Given this list of marker genes IDUA, here is a description of the gene set: studied in species Homo sapiens Mucopolysaccharidosis type I (MPS I, Hurler syndrome, Hurler's disease, gargoylism, Scheie, Hirler-Scheie syndrome; MIM:607014, 607015 and 607016) is an autosomal recessive genetic disorder where there is a deficiency of alpha-L iduronidase (IDUA, MIM:252800), a glycosidase that removes non-reducing terminal alpha-L-iduronide residues during the lysosomal degradation of the glycosaminoglycans heparan sulphate and dermatan sulphate. In 1992, Scott and colleagues were able to clone and purify the gene that encodes this enzyme, IDUA, demonstrating that it spans approximately 19 kb and contains 14 exons.<br>Hurler syndrome is named after a German paediatrician Gertrud Hurler (1919, no reference available). The result is build up of heparan sulfate and dermatan sulfate in the body and increased urinary excretion of these GAGs. Symptoms and signs include hepatosplenomegaly, dwarfism, unique facial features, corneal clouding, retinopathy, progressive mental retardation appears during childhood and early death can occur due to organ damage (Campos & Monaga 2012). MPS I is divided into three subtypes, ranging from severe to mild phenotypes; Mucopolysaccharidosis type IH (MPSIH, Hurler syndrome, MIM:607014), mucopolysaccharidosis type IH/S (MPSIH/S, HurlerScheie syndrome, MIM: 607015) and mucopolysaccharidosis type IS (MPSIS, Scheie syndrome, MIM: 607016) respectively. part of: Mucopolysaccharidoses Reactome Pathway: MPS I - Hurler syndrome (HS-GAG degradation)